The following is a description of a gene set: Catalysis of the reaction: RSO-R' + H2O = RSOOH + R'H. This reaction is the hydrolysis of a sulfuric ester bond, an ester formed from sulfuric acid, O=SO(OH)2. Human Gene Set: GOMF_SULFURIC_ESTER_HYDROLASE_ACTIVITY species: Homo sapiens, and this is the list of marker genes: ARSJ, SULF2, IDS, ARSA, ARSL, ARSD, ARSH, SULF1, ARSG, SGSH, GNS, GALNS, ARSI, STS, ARSB, ARSF, ARSK